Given this list of marker genes Rps7, Map2k2, Rnaset2b, Arpc1b, Anxa2, Ptma, Eif3f, Tle5, Znhit1, Trir, Ctsz, Atp6v0c, Gstm1, Wbp2, Lgals3, Rpl4, H2-Aa, Pebp1, Bbc3, Ubb-ps, Tmed9, Rhoc (ras homolog family member C), H2-DMb1, H2-Eb1, Kdm6b, Rpl13a, Lamtor4, Lyz1, Ssbp4, Tex261, Tmed3, Nfkbia, Map1lc3a, Selenom, Gadd45g, Scand1, Jund, Arpc3, H2-K1, Cd209f, Acp5, C4b, Sparc, C1qa, Tspan32, Spi1 (NCBI Gene Id 20375), Rpl6, Cdc123, Tmem160, Pfn1, Srsf5, Drap1, Cd72, Ccdc124, Phb2, Dcn, Zfp710, Cfl1, Lilrb4a, Arrb2 (NCBI Gene Id 216869), Dpt, Rbm3, Cxcl2, Arhgdia, Slc25a5, H3f3b, Tomm6, Tmsb10, Fdps (farnesyl diphosphate synthetase), Ptms, Plekho1, Grina, Ccdc80, Slc2a5, Cxcl13, Oaz1, Prr13, Rps3, Ier2, Erp29, Cyba, Anxa1, Ifitm2, Basp1, Csf2ra, Spr, Metrnl, Cotl1 (coactosin like F-actin binding protein 1), Cnnm4, Mgp, Siglech, H2-Ab1, Rplp0, Snrpc, Abi3, Rpl3, S100a6, Ifi30, Sdhc, Crlf2 (NCBI Gene Id 57914), Id3, Dpysl2, Bsg, Ier3, Ppp1r11 (NCBI Gene Id 76497), Vsig4, Ecm1, Cxcl1, Gngt2, Slc25a3 (solute carrier family 25 (mitochondrial carrier, phosphate carrier), member 3), Il1b (NCBI Gene Id 16176), Lum, Cox5a, Sf3b4, Ftl1, Eif5a, Bcl7c, H2-M2, Lamtor1, Tbcb, Skil (NCBI Gene Id 71615), Vim, Ubald1, Cd9, Il2rg, Tnfsf13, Gnb1, Psmb8, Emc10, Mgst1, Capg, Mmp12, Sdc4, Efhd2, Fxyd5 (NCBI Gene Id 18301), Gpx3 (NCBI Gene Id 14778), Ifi27, Shisa5, Bri3, here is a description of the gene set: from publication Tabula Muris Consortium (PMID 32669714) Mouse Gene Set: TABULA_MURIS_SENIS_HEART_MONOCYTE_AGEING studied in species Mus musculus